Given this list of marker genes LCP1, PRPSAP2, CCDC144A, CPNE3, SUSD3, HOPX, NEIL1, BASP1, PARP1, RFTN1, LMO2, CD40, TCL1A, MTF2, JCHAIN, TMEM123, PPP2CA, SYNE2, LPP, RGS13, HMGN1, HMCES, BCL7A, UBE2J1, GGA2, SERPINA9, LCK, BCAS4, DBI, ABRACL, IRAG2, GCHFR, P2RX5, DAAM1, CD22, MARCKSL1, RNGTT, STAG3 (STAG3 cohesin complex component), RGS1, PRDX6, KLHL6, HMGA1, POU2AF1, UCP2, LAT2, GRHPR, FAM3C, CD79B, ACTG1, CCDC88A, here is a description of the gene set: Human Gene Set: GAVISH_3CA_METAPROGRAM_B_CELLS_GERMINAL_CENTER from publication Gavish A, Tyler M, Greenwald AC, Hoefflin R, Simkin D, Tschernichovsky R, Galili Darnell N, Somech E, Barbolin C, Antman T, Kovarsky D, Barrett T, Gonzalez Castro LN, Halder D, Chanoch-Myers R, Laffy J, Mints M, Wider A, Tal R, Spitzer A, Hara T, Raitses-Gurevich M, Stossel C, Golan T, Tirosh A, Suvà ML, Puram SV, Tirosh I (PMID 37258682) In this study, an extensive analysis was conducted to define meta-programs (MPs) capturing intra-tumor heterogeneity across a spectrum of tumor types. The approach utilized non-negative matrix factorization (NMF) to analyze each cell type separately within individual tumor samples. This involved the analysis of malignant cells, macrophages, fibroblasts, endothelial cells, epithelial cells, T-cells, and B-cells. NMF was executed with varying parameter values (K=4, 5, 6, 7, 8, 9), thereby generating 39 programs for each cell type per sample. Each NMF program was summarized by the top genes based on NMF coefficients.\nRobust MPs were then delineated for each cell type using a set of stringent criteria, including recurrence within the same tumor, similarity to programs in other tumors, and non-redundancy within a tumor. Subsequently, these robust NMF programs were clustered (per cell type) based on Jaccard similarity, leading to the identification of MPs associated with each cell type.\nTo enhance the quality of the MPs, a refinement steps were undertaken, involving the removal of MPs suspected of reflecting low-quality data (with an overrepresentation of ribosomal proteins or mitochondrial-encoded genes), single-study inclusion, or similarity to miss-annotated cell types. studied in species Homo sapiens Genes upregulated in subsets of cells of a given type within various tumors